Given this list of marker genes STK36, DNAAF5, DNAH11, NME8, DNAAF3, CCDC65, ODAD2, CCDC40, ODAD1, RSPH9, HYDIN, DNAL1, DNAJB13, CFAP300, RSPH4A, RSPH3, DNAAF2, DNAH5, TTC12, ODAD3, DNAI1 (dynein axonemal intermediate chain 1), ZMYND10 (zinc finger MYND-type containing 10), CCDC103, CCDC39, DNAI2, DNAAF11, DNAH9 (NCBI Gene Id 8709), SPAG1, DNAAF4, CFAP298, CFAP74, CCNO, DNAAF1, GAS8, RSPH1, DRC1, here is a description of the gene set: Any functional anomaly of the respiratory motile cilia. Abnormal respiratory motile cilium physiology species: Homo sapiens Human Gene Set: HP_ABNORMAL_RESPIRATORY_MOTILE_CILIUM_PHYSIOLOGY